Given this list of marker genes NRF1, RAP1B, TMEM250 (transmembrane protein 250), SLC6A20, CLN8, CDK9, RAB1B, DCANP1, here is a description of the gene set: from publication Chen Y, Wang X (PMID 31504780) studied in species Homo sapiens Human Gene Set: MIR4485_5P Genes predicted to be targets of miRBase v22 microRNA hsa-miR-4485-5p in miRDB v6.0 with MirTarget v4 prediction scores > 80 (high confidence targets).